The following is a description of a gene set: Any process that modulates the frequency, rate or extent of Wnt signaling pathway, planar cell polarity pathway. species: Homo sapiens Human Gene Set: GOBP_REGULATION_OF_WNT_SIGNALING_PATHWAY_PLANAR_CELL_POLARITY_PATHWAY, and this is the list of marker genes: GPC3, ZNRF3, NPHP3, DAB2, RSPO3, NKD1, DKK1, PLEKHA4, ABL1, SPEF1, DACT1, MKS1, MLLT3, ANKRD6